The following is a description of a gene set: species: Homo sapiens Human Gene Set: GOBP_REGULATION_OF_CELLULAR_SENESCENCE Any process that modulates the frequency, rate or extent of cellular senescence., and this is the list of marker genes: SIRT1, CDK6, MIF, MORC3, TWIST1, MIR590, SUV39H1, RSL1D1, TP53, HLA-G, MIR10A, PAWR, ZKSCAN3, MIR17, B2M, ING2, TP63, PLK2, CGAS, ARG2, TBX2, RBL1, MIR146A, YBX1, TERC, WNT1, FZR1, MIR217, BMAL1, NEK4, HMGA2, ZNF277, FBXO5, KIR2DL4, KRAS, MIR543, NEK6, VASH1, TERF2, MIR34A, BMPR1A, EEF1E1, YPEL3, ABL1, BCL6, NUAK1, PNPT1, ZMPSTE24 (NCBI Gene Id 10269), BCL2L12, PTEN, AKT3, MIR22, TERT, SIRT6, MIR20B, ABI3